Given this list of marker genes ABCB6, FXYD2, ATP1A4, ATP1B3 (NCBI Gene Id 483), FXYD4, ATP6V1G2, ATP4B, FXYD1, SPAAR, ATP4A, ATP6V0E2, ABCB8, ABCA2, ATP6V0A2, ATP6V1G1, ATP1B1, ATP6V0E1, ABCC9, ATP1B2, KCNJ8 (potassium inwardly rectifying channel subfamily J member 8), ATP6V1F, ATP6V1G3, ABCG5, ABCC8, ATP6V1C1, ABCD4, ATP6AP2, ATP6V1E1, ATP6V0D1, TCIRG1, TMEM199, ATP6V0A4, ATP2A2, PLN, ABCG8, ATP6V1A, ATP1A1, ATP1A3, ATP6V0A1, ATP1B4, ATP6V0B, ATP1A2, ATP6V1B1, ATP6V0C, CCDC115, ATP6V1C2, ATP6V0D2, SLC9A1, ATP6V1B2, RNASEK, ATP6V1H, ATP12A, ATP6AP1, ATP6V1D, here is a description of the gene set: Human Gene Set: GOCC_ATPASE_DEPENDENT_TRANSMEMBRANE_TRANSPORT_COMPLEX A transmembrane protein complex that functions in ATPase dependent active transport across a membrane. species: Homo sapiens